The following is a description of a gene set: Mouse Gene Set: MIR_6952_3P Genes predicted to be targets of miRBase v22 microRNA mmu_miR_6952_3p in miRDB v6.0 with MirTarget v4 prediction scores > 80 (high confidence targets). species: Mus musculus from publication Chen Y, Wang X (PMID 31504780), and this is the list of marker genes: Tpp2, Rab1a, Eif2s2, Rassf3 (NCBI Gene Id 216391), Dact3 (dishevelled-binding antagonist of beta-catenin 3), Erg, Sstr1, Npas3, Zfp12, Scarb2, Narf, Ptprb, Nipal1, Prps2, 4930563E22Rik, Tmem88, Clcn1 (chloride channel, voltage-sensitive 1), Tspan18, Cdin1, Xpo6, Pitpnb, Leap2, Zfp979, Gpr35, Lmln, Ilf3, Cemip, Vamp4, Pip4p2, Nfyb, Bcl2l14, Traf3, Arvcf, Pnpla5, Foxj2, Atp2a3, Rhot1, Akap17b (NCBI Gene Id 338351), Set, Wbp1l, Ifi27l2b, Vps50, Ikbkb, Rras2, Nr2c2 (NCBI Gene Id 22026), Unc5d, Bmp2, Med14, Wdr76 (WD repeat domain 76), Nomo1, Supt7l, Tmem132b, Fcna, Gfra1, Usf3, Xpc, Ttc4, Zfp626, Dixdc1, Ptgfr, Mc1r, Ly6c1, Zc3h13, Itgb2, Abca5, Elk1, Bnc2, Stx3, Rora, Srf, Spcs2, Rspry1